Given this list of marker genes SLAMF8, RPS19, DUSP10, INS, GRN, here is a description of the gene set: Any process that decreases the rate, frequency or extent of a phase of elevated metabolic activity, during which oxygen consumption increases made as a defense response; this leads to the production, by an NADH dependent system, of hydrogen peroxide (H2O2), superoxide anions and hydroxyl radicals. species: Homo sapiens Human Gene Set: GOBP_NEGATIVE_REGULATION_OF_RESPIRATORY_BURST_INVOLVED_IN_INFLAMMATORY_RESPONSE